Given this list of marker genes Akap5, Chp1, Ppp3r1, Nfatc3, Nrg1, Rcan1, Adgrb2, Calm2, Calm1, Dyrk2, Fhl2, Plcg2, Nfatc2, Chp2, Mtor, Camta1, Nr5a2, Slc8a2, Nfam1, Cmya5 (NCBI Gene Id 76469), Gsk3b, Igf1, 3425401B19Rik, Nfatc4, Ptbp1, Clec7a, Lmcd1, Rcan2, Homer2, Akap6, Myoz1, Efhb, Cherp, Nron, Calm3, Tbc1d10c, Mir1a-1, Myoz2, Orai1, Prnp, Nfat5, Nr5a1, Atp2b4, Ppp3cc, Tprg1l, Ppp3ca, Tnf, Nfatc1, Cyp19a1, Homer3, Erbb3, Mapk7, Slc9a1, Mir1a-2, Actn3, Ppp3cb, Cib1, Dyrk1a, Ppp3r2, Sppl3, here is a description of the gene set: Mouse Gene Set: GOBP_CALCINEURIN_MEDIATED_SIGNALING studied in species Mus musculus Any intracellular signal transduction in which the signal is passed on within the cell by activation of a transcription factor as a consequence of dephosphorylation by Ca(2+)-activated calcineurin. The process begins with calcium-dependent activation of the phosphatase calcineurin. Calcineurin is a calcium- and calmodulin-dependent serine/threonine protein phosphatase with a conserved function in eukaryotic species from yeast to humans. In yeast and fungi, calcineurin regulates stress signaling and cell cycle, and sporulation and virulence in pathogenic fungi. In metazoans, calcineurin is involved in cell commitment, organogenesis and organ development and immune function of T-lymphocytes. By a conserved mechanism, calcineurin phosphatase activates fungal Crz1 and mammalian NFATc by dephosphorylation and translocation of these transcription factors to the nucleus to regulate gene expression.